The following is a description of a gene set: Genes down-regulated in CD8 T cells: control versus stimulated by IFNA2. IFN alpha mediated gene expression pattern. The effect of IFN alpha on human CD8 T cells responding to antigen (signal 1) and costimulatory signals (signal 2) provided by beads coated with anti-CD3 and anti-CD28 mAbs. This analysis examined the effects of IFN alpha on human CD8 T cells responding to antigen (signal 1) and costimulatory signals (signal 2) provided by beads coated with anti-CD3 and anti-CD28 mAbs. Magnetically sorted untouched CD8+CD45R0- T cells from three different donors were unstimulated or stimulated with IFNa2b or with anti-CD3/CD28 Beads alone or along with IFNa2b or IFNa5 for 48 hours. Individual mRNA samples were analyzed using HG-U133A 2.0 array gene chips. Human Gene Set: GSE17301_CTRL_VS_48H_IFNA2_STIM_CD8_TCELL_DN from publication Hervas-Stubbs S, Riezu-Boj JI, Gonzalez I, Mancheño U, Dubrot J, Azpilicueta A, Gabari I, Palazon A, Aranguren A, Ruiz J, Prieto J, Larrea E, Melero I (PMID 21108462) studied in species Homo sapiens, and this is the list of marker genes: H2AC15, TRAC, ARHGEF7, GMEB2, MBTD1, NMU, KIF21B, SUN2, HSD17B6, CRYL1, ARAP1, RIPK4, KDM5C (NCBI Gene Id 8242), SPSB3, EPHB6, GLTP, RETREG1, PBXIP1, USP20, GPRASP1, ZNF337, SLAMF1, PLS1, S100A10, SLC36A1, AGER, ZNF133, CD8B, PIK3C2B, CAPN10, ANKRD36BP2, XYLT2, RAB32, STIMATE, PACS1, CNPY4, STON1, RORC, SETD1B, TRBC1, KIAA0753, FABP4, KLF12, TRBV10-2, CHMP7, KLF7, SCN8A, VPS37A, CBFA2T2, BRD9, ACSBG1, SUGP1, UPB1, PRKCG, INPP5K, ADCY8, COQ6, CD1C, NPPC, MARCHF3, POR, TINF2, CASK, MFGE8, GSS, UCN, KDM4C, BCL6, CLCN4, NEIL1, C10orf88, ZFTRAF1, BMAL1, MXD3, H2BC15, CD8A, TAFAZZIN, MED25, HDAC7, HOXB2, SLC7A10, CEP85, AKAP3, FBLN5, CIC, PLXNB1, SOX30, SLA, IRX5, PLPPR2, ARFGAP1, CCHCR1 (NCBI Gene Id 54535), FSD1, BNIP1, REEP4, SPATA2L, GRAMD1C, ITM2A, GLA, ECE1, ATG4B (autophagy related 4B cysteine peptidase), NSMF, ING4, CDR1, MAST4, ENC1, PHF1, ABCC5, ACTR1B, MACF1, TENM1, SIT1, AQP3, NDE1, ACTB, CDC42EP3, DDAH1, UNKL, KCNA3 (NCBI Gene Id 3738), FSTL1, MPPE1, NOS2, ITIH4, TESK1, ZNF587, CTC1, ESRP2 (NCBI Gene Id 80246, epithelial splicing regulatory protein 2), SATB1, HIVEP2, RGL2, CEP164, GTSE1, CD52, APBB1, PTGDR2, RBM38, STK32B, PTPRK, SFI1, IGLV4-60, CDKN2C, PCYT2, CXCL11 (C-X-C motif chemokine ligand 11), ZW10, THAP3, GABRB3, TLL1, POGLUT1, SLC29A2, MAP6D1, ABCA7, ACKR4, H4C1, CARMIL1, PRR11, IL1A, POLH, DUSP8, PRR14, SAGE1, SLC16A2, ARAP2, SPOCK2, SH3GL3, ZNF562, PLXDC1, MR1, TBC1D17 (TBC1 domain family member 17), H2BC14, GDI1, ARHGEF1, GAREM1, TRIB2, PTK2B, RUSC1, LMF2, SKAP1, MYO9B, NIBAN1, CYB5R1, ADRA1B, HKDC1, LMBR1L, LRCH4, H1-5, RHOT2, TSPAN4, ARL4A, VPS37C, ENTPD6, CD247, IL32, NCAPH2, SIPA1, CD72, ATP1B4